The following is a description of a gene set: Human Gene Set: BACH2_01 species: Homo sapiens Genes having at least one occurrence of the motif SRTGAGTCANC in the regions spanning 4 kb centered on their transcription starting sites. This matches the BACH2 transcription factor binding site V$BACH2_01 (v7.4 TRANSFAC)., and this is the list of marker genes: PVALB, SPATS2, HSPB8, SYNPO, CSF3, PADI4, EFNA1, MAP3K6, DMD (NCBI Gene Id 548327), APOBEC1, TAGLN2, LMNA, LPCAT3, LAMC2, CDKN1A, SLC26A9 (solute carrier family 26 member 9), MNT, VASP, PCSK1, ADRA1A, MMP9, COL5A3, ARIH1, EN1, SLC41A1, TXLNG, CHMP4B, TENM3-AS1, CALB2, CLDN16, TRPV3, RAB34, ZCWPW1, ADGRG1, EDEM1, DSC2 (desmocollin 2), STAT5B (NCBI Gene Id 6777), ROM1, PSME4, CIMAP2, TAF15, TNXB, HBEGF, PLEKHH3, FOXA1 (NCBI Gene Id 3169), SYP, PLEC, VDR, BAZ2A, TFE3 (transcription factor binding to IGHM enhancer 3), SPTA1, NLK, TFIP11, NDRG2, EML3, LINC03042, SLC9A8, AKT3, MEPCE, PKN3, CDK6, LINC00649, ELL (elongation factor for RNA polymerase II), ENO1, ALDOA, SLC4A11, TNRC6A, RIN1, CLC, CMAS, NTN4, SFTPC, RPL23A, ITGB4, RNF34, ITPKC, PRDM1, SFN, CRACDL, EIF4E, GPX1, EPHB2, DTX2, CILK1, LUC7L, TNFRSF12A, RPS20 (ribosomal protein S20), SNCB, REXO2, NCS1, ACADVL, TENT5B, LPP, MYH14, UBE2E3 (ubiquitin conjugating enzyme E2 E3), LRCH4, NR4A1, UCN2, COQ8B, SMARCD1, PSMD4, RNF182, DNAJC5B, XPOT, PADI3, TINAGL1, FGF11, ABTB3, EIF4G1, BDKRB1, IL11 (interleukin 11), CAPN6, YPEL5, BLMH, UBALD1, GFAP, CDH23 (NCBI Gene Id 7395), DIRAS1, RTN4, DLG4, MMP19, SGIP1, KRT16, SHC3, SLC26A1, NCDN, ENO2 (enolase 2), KCNA2, GPAT3, SEC24D, RUNDC3A, SYT2 (synaptotagmin 2), CA7, MAMDC2, C1orf220, NUP155, GRIA1, CHST1, ASS1, GKN1, DHRS3, CA9, CAPNS1, TNKS2, PPP1R9B, LAMA3, GNGT2, RTL9, RIT1, SMS, HOXB6, LRRC15, PSMD11 (proteasome 26S subunit, non-ATPase 11), CHST4, CRYBA2, TMCC1 (transmembrane and coiled-coil domain family 1), ABI3, PROK2, FADS3, RHOC, CYTOR, SGK1, CSMD3, TRAK2, CCL27, LY6G6C, GASAL1, LDB3, LRRC8E, BICDL1, HIVEP3, ATF4, KBTBD8, SLC39A13, MMP1, MIDEAS, BCL9L, STRADB, COL7A1, FAM180A, GDNF, TUBB4A, S100A2, SERTAD1, NUAK1 (NCBI Gene Id 9891), RASD1, GABARAPL1, GADD45B, MYB, MPV17, PACSIN3, BRD2, PRKAR2A, DDIT3, POLR3E, HDAC3, RELL2 (RELT like 2), KDM3A, TRIB1, AKAP1, BACH1, SCRN1, BMP2, DUSP14, TIAL1, ZBTB43, CLIC1, ABCF3, SLC16A6, CAMKK1, PTPRN, RAB3D, CLRN1, NR0B2, EIF3J, RPLP0, DYNC1H1, DYSF, NDEL1, UBQLN1, OR2F1, CSRNP1, F2RL2 (NCBI Gene Id 2151), GAPDH, ABCD1 (NCBI Gene Id 215), GFI1, TRIM9, LINC02694, PRX, STMN2, RAB30, PEA15, P2RX6, SAMD12, SLC6A5, PPP2CA, EEF1A1 (NCBI Gene Id 96648), PRSS36, CCDC120, USP14, GPR3, PCDH17, CIDEC, MAPRE3, CAB39, NOL10 (nucleolar protein 10), S1PR2, CPA6, FBXO24, HS3ST2 (heparan sulfate-glucosamine 3-sulfotransferase 2), HS3ST3B1, DENND1B, PHLDA2, NR1D1, PIM1, USP3, RNF10, ZNF23, TUBA1C, ZNF827, RGS2, DCLK1, COL27A1, CTNNAL1, LRRN3, RIMS1, ACP3, CAPN12, SCOC, MMP7, RNF144B, DDX17, GADD45A